Given this list of marker genes FMR1, FXR1, EIF4H, EIF4B, DDX3X, here is a description of the gene set: Human Gene Set: GOMF_RNA_STRAND_ANNEALING_ACTIVITY species: Homo sapiens An activity that facilitates the formation of a complementary double-stranded RNA molecule.